The following is a description of a gene set: Human Gene Set: MIR3680_5P Genes predicted to be targets of miRBase v22 microRNA hsa-miR-3680-5p in miRDB v6.0 with MirTarget v4 prediction scores > 80 (high confidence targets). studied in species Homo sapiens from publication Chen Y, Wang X (PMID 31504780), and this is the list of marker genes: CLXN, SLBP, USP32 (NCBI Gene Id 84669), DNER, MED6, SLC35A1 (solute carrier family 35 member A1), TASOR, FUT10, TRABD2A, OGN, ARID4A, CSNK1G1, ELAVL4, BAG4, TMED7, PLCL1, LARP4B, ERCC1, TXNDC16, PDS5B, ANKIB1, PLPPR4, USP46, ERC2, HOOK1, COL14A1, COMMD10, GNRHR, SS18L1, ALPI, GATA2, NFAT5, SLIT3, LIFR